Given this list of marker genes LRPAP1, ROCK1, IL4, TTPA, TREM2, ABCA7, LRP1, APOE (apolipoprotein E), here is a description of the gene set: studied in species Homo sapiens Human Gene Set: GOBP_POSITIVE_REGULATION_OF_AMYLOID_BETA_CLEARANCE Any process that activates or increases the frequency, rate or extent of amyloid-beta clearance.